Given this list of marker genes TNFAIP3, IGF2, ATF3, NFKB1, ISG20, LAMA1, MMP1, ITGA2 (integrin subunit alpha 2), SOX9, STC1 (stanniocalcin 1), here is a description of the gene set: Mammary epithelial cells are embedded in a unique extracellular environment to which adipocytes and other stromal cells contribute. Mammary epithelial cells are critically dependent on this milieu for survival. However, it remains unknown which adipocyte-secreted factors are required for the survival of the mammary epithelia and what role these adipokines play in the process of ductal carcinoma tumorigenesis. Here, we take a systematic molecular approach to investigate the multiple ways adipocytes and adipokines can uniquely influence the characteristics and phenotypic behavior of malignant breast ductal epithelial cells. Microarray analysis and luciferase reporter assays indicate that adipokines specifically induce several transcriptional programs involved in promoting tumorigenesis, including increased cell proliferation (IGF2, FOS, JUN, cyclin D1), invasive potential (MMP1, ATF3), survival (A20, NFkappaB), and angiogenesis. One of the key changes in the transformed ductal epithelial cells associated with the cell cycle involves the induction of NFkappaB (five-fold) and cyclin D1 (three-fold). We show that by regulating the transcription of these molecules, the synergistic activity of adipocyte-derived factors can potentiate MCF-7 cell proliferation. Furthermore, compared to other stromal cell-secreted factors, the full complement of adipokines shows an unparalleled ability to promote increased cell motility, migration, and the capacity for angiogenesis. Adipocyte-secreted factors can affect tumorigenesis by increasing the stabilization of pro-oncogenic factors such as beta-catenin and CDK6 as a result of a reduction in the gene expression of their inhibitors (i.e. p18). An in vivo coinjection system using 3T3-L1 adipocytes and SUM159PT cells effectively recapitulates the host-tumor interactions in primary tumors. Type VI collagen, a soluble extracellular matrix protein abundantly expressed in adipocytes, is further upregulated in adipocytes during tumorigenesis. It promotes GSK3beta phosphorylation, beta-catenin stabilization, and increased beta-catenin activity in breast cancer cells and may critically contribute towards tumorigenesis when not counterbalanced by other factors. Human Gene Set: IYENGAR_RESPONSE_TO_ADIPOCYTE_FACTORS from publication Iyengar P, Combs TP, Shah SJ, Gouon-Evans V, Pollard JW, Albanese C, Flanagan L, Tenniswood MP, Guha C, Lisanti MP, Pestell RG, Scherer PE (PMID 14508521) studied in species Homo sapiens Genes up-regulated in MCF-7 cells (breast cancer) in response to growth medium from L3T3-L1 cells (differentiated to pre-adipocytes).